Given this list of marker genes SLC26A8, SLC26A6, SLC26A5, SLC26A11 (NCBI Gene Id 65011), SLC26A2, SLC13A4, SLC26A1, SLC26A4, SLC13A1, UCP2, SLC26A3, here is a description of the gene set: Human Gene Set: GOMF_SECONDARY_ACTIVE_SULFATE_TRANSMEMBRANE_TRANSPORTER_ACTIVITY studied in species Homo sapiens Enables the secondary active transfer of sulfate from one side of a membrane to the other. Secondary active transport is the transfer of a solute across a membrane, up its concentration gradient. The transporter binds the solute and undergoes a series of conformational changes. Transport works equally well in either direction and is driven by a chemiosmotic source of energy. Secondary active transporters include symporters and antiporters.